Given this list of marker genes Fhit, Kars1, Nudt3, Nudt11, Nudt10, Mapk1, Nudt4, Gars1, here is a description of the gene set: The chemical reactions and pathways involving diadenosine polyphosphate, a derivative of the nucleoside adenosine with phosphate groups attached. Mouse Gene Set: GOBP_DIADENOSINE_POLYPHOSPHATE_METABOLIC_PROCESS studied in species Mus musculus